The following is a description of a gene set: species: Homo sapiens part of: Gastrulation Reactome Pathway: Specification of the neural plate border The neural plate border forms on the dorsal side of the embryo between the medial neural plate and the lateral epidermis. This region has intermediate BMP and FGF signaling, with WNT also playing a role in specification. Within the neural plate border, FGF signaling appears to repress formation of epidermis while BMP appears to repress formation of neural cells. During neural plate border specification, the most anterior part is a WNT-free domain and the posterior part is exposed to WNT activity.<br>As the neural plate folds to form the neural tube, the neural plate border contributes to the olfactory, lens, and hypophyseal placodes in the anterior region and the neural crest in the posterior region. In addition, the otic placodes and cranial sensory placodes arise immediately lateral to the neural crest. The neural crest is a population of migratory cells located dorsal to the neural tube that is unique to vertebrates and gives rise to several cell types, including neurons and glia of the peripheral nervous system, osteoblasts and chondrocytes of the craniofacial skeleton, adrenal medulla cells, and melanocytes. Placodes generate the olfactory epithelium, the lens of the eye, the inner ear, the endocrine adenohypophysis of the pituitary gland, and some neurons of the cranial sensory ganglia.<br>The neural plate border is specified by a combination of transcription factors including GBX2, TFAP2A, MSX1, MSX2, ZIC1, ZIC3, DLX5/6, PAX3, and PAX7. These factors may also be expressed in additional, overlapping regions. For example ZIC1 is expressed in the neural plate border and more medially in the neural plate, where it is involved in neural induction. TFAP2A is expressed in the neural plate border and more laterally in the epidermis. Thus the neural plate border is defined by a combination of factors rather than by a single factor.<br>The order of expression of neural plate border specifiers is not completely characterized in humans. In human embryonic stem cells differentiated in vitro, GBX2 is expressed broadly in the posterior ectoderm, then TFAP2A, PAX3, PAX7, and MSX1 are expressed in a neural plate border state. The primacy of Gbx2 is also observed in Xenopus embryos. These genes then cross-regulate each other's expression to create a self-reinforcing module., and this is the list of marker genes: MSX1, POU5F1, SOX2, PAX7, FGF4, GBX2, WNT3A, CTNNB1, BMP4, PAX3 (NCBI Gene Id 5077), DLX5, TFAP2C, TFAP2A, MYB, TFAP2B, TCF7L1, ZIC1